The following is a description of a gene set: species: Mus musculus part of: Fertilization This event has been computationally inferred from an event that has been demonstrated in another species.<p>The inference is based on the homology mapping from PANTHER. Briefly, reactions for which all involved PhysicalEntities (in input, output and catalyst) have a mapped orthologue/paralogue (for complexes at least 75% of components must have a mapping) are inferred to the other species. electronically inferred by orthology from the curated human pathway Reactome Pathway: Interaction With Cumulus Cells And The Zona Pellucida, and this is the list of marker genes: Zp3, Adam21, Adam30, Adam2, Hyal5, Zp1, Zp2, Adam25